The following is a description of a gene set: Human Gene Set: KEGG_MEDICUS_REFERENCE_CRHR_PKA_ACTH_SIGNALING_PATHWAY CRHR-PKA-ACTH signaling pathway. Pathway ID: N00324. Pathway type: Reference. Pathway class: nt06310 CRH-ACTH-cortisol signaling. species: Homo sapiens Pathway Definition from KEGG: CRH -> CRHR -> GNAS -> ADCY -> cAMP -> PKA -> CREB -> ACTH, and this is the list of marker genes: ADCY6, CREB3L4, ADCY7, POMC, CRHR1, ATF6B, CREB5, ADCY2, PRKACG, ADCY5, CRHR2, CREB3, GNAS, PRKACA, ADCY9, CREB1, CREB3L1, ADCY8, PRKACB, CREB3L2, ATF2 (activating transcription factor 2), ADCY3, CRH, CREB3L3, ADCY1, ADCY4, ATF4